Given this list of marker genes Gpc1, Pitx2, Wt1, Kifap3, Afap1, Pdzrn3, Adgrl1, Ptn, Rhob, Tbx3, Uchl3, Cd248, Tmem47, Marcksl1, Wls, Tgif1, Asb4, Prrx2, Slc12a2, Pogk, Ptprs, Lpar4, Fgfr1, Tmem50b, Gas1, Tro, Lrp12, Rarb (NCBI Gene Id 218772), Crabp2, Bysl, Pfn2, Ppic, Rbm34, Pfdn4, Mfap2, Prph2 (NCBI Gene Id 19133), Spats2, Rprm, Mdk, Hba-x, Hmgn1, Socs6, Pcolce2, Armcx2 (NCBI Gene Id 67416), Polr1e, Col5a2, Mak16, B4galt2, Pno1, Ptbp2, Hmga2, Dlg3, Evl, Pdzd2, Cdk14, Nr2f1, Hdac2, Hmgn3, Ctbp2, Mycn, Mest, Syne2, Morf4l1, Ttc3, Fgf13, Pdgfc, Ctps1, Ifrd1, Snn, Jun, Trps1 (transcriptional repressor GATA binding 1), Npas2, Adgrl2, Hand2, Fam136a, Mgat5 (mannoside acetylglucosaminyltransferase 5), Cpm, Nes, Fam174b, Sema3d (sema domain, immunoglobulin domain (Ig), short basic domain, secreted, (semaphorin) 3D), Lrfn4, Tspan6, Emcn, Capn6, Kctd15, Gdf10, Srsf7, Hbb-y, Tgfb2, Grwd1, Septin6, Rwdd1, Rnf138, Wasf1, Sh3gl3, Cst6, Itga8, Tmeff1, Tmem184c, Basp1, Bnc1, Heph, Armcx1, Obi1, Gja1, Igfbp5, Smyd2, Ednrb, Tulp4, Rcn1, Pxdn, Large1, Satb1, Gjc1, Slc22a3, Plod2, Map4k1, Reck, Nnat, Rcn2 (reticulocalbin 2), Fzd2, Flrt3, Pafah1b3, Serpine2, Fkbp10, Rrp8, Golt1b, Csrp2, Neo1 (neogenin), Id3 (NCBI Gene Id 15903), Smarca2 (NCBI Gene Id 67155), Serpinh1, Arpp19, Srm, Akt3 (NCBI Gene Id 98462), Smarcd3, Tbcb, Plk2, Pdpn, Efnb2, Pdgfra, Cdh16, Colec12, Slc39a6, Klhl22, Pgk2, Cysltr1, Ndn, Zfp423, Ccn4, Pkm, Ackr3, Cbfb, Igf2bp2, Slc25a4, Rab11fip3, Utp3, Fkbp3, Pls3, Ehbp1, Ldb2, Smarca1, Tspyl4, Lxn, Mex3d, Sema3a, here is a description of the gene set: studied in species Mus musculus Genes up-regulated at early fetal liver stage (embryonic days E11.5 - E12.5) compared to the late fetal liver stage (embryonic days E14.5 - E16.5). Mouse Gene Set: CAIRO_LIVER_DEVELOPMENT_UP from publication Cairo S, Armengol C, De Reyniès A, Wei Y, Thomas E, Renard CA, Goga A, Balakrishnan A, Semeraro M, Gresh L, Pontoglio M, Strick-Marchand H, Levillayer F, Nouet Y, Rickman D, Gauthier F, Branchereau S, Brugières L, Laithier V, Bouvier R, Boman F, Basso G, Michiels JF, Hofman P, Arbez-Gindre F, Jouan H, Rousselet-Chapeau MC, Berrebi D, Marcellin L, Plenat F, Zachar D, Joubert M, Selves J, Pasquier D, Bioulac-Sage P, Grotzer M, Childs M, Fabre M, Buendia MA (PMID 19061838) Hepatoblastoma, the most common pediatric liver cancer, is tightly linked to excessive Wnt/beta-catenin signaling. Here, we used microarray analysis to identify two tumor subclasses resembling distinct phases of liver development and a discriminating 16-gene signature. beta-catenin activated different transcriptional programs in the two tumor types, with distinctive expression of hepatic stem/progenitor markers in immature tumors. This highly proliferating subclass was typified by gains of chromosomes 8q and 2p and upregulated Myc signaling. Myc-induced hepatoblastoma-like tumors in mice strikingly resembled the human immature subtype, and Myc downregulation in hepatoblastoma cells impaired tumorigenesis in vivo. Remarkably, the 16-gene signature discriminated invasive and metastatic hepatoblastomas and predicted prognosis with high accuracy.